The following is a description of a gene set: species: Homo sapiens Any process that modulates the frequency, rate or extent of leukocyte proliferation. Human Gene Set: GOBP_REGULATION_OF_LEUKOCYTE_PROLIFERATION, and this is the list of marker genes: IGF2, RIPK2, PRKAR1A, PRNP, TNFSF8, MYD88, TMEM131L, IL6ST, VAV3 (vav guanine nucleotide exchange factor 3), CBLB, TNFRSF14, IL34, BCL6, GSTP1, NMBR, CD6, MAD1L1, KITLG, CCL8, IL4, HLA-DPB1, MARCHF7, DNAJA3, ITCH, BMI1, DHPS, TACR1, CDKN2A, CD38, LGALS3, MPL, LILRB2, MIR21, IL23R, EBI3, LST1, ATM, SLAMF1, FADD, TGFBR2, CRTAM, GNRH1, MIR181C, IRS2, ZP3, PLA2G2F, JAK2, HES1, HAVCR2, CD86, TNFSF18, GPAM, EPHB2, TGFB1, TMIGD2, PRLR, IGFBP2, GPNMB, CD40LG, CD55, CTNNB1, HMGB1, CD80, CASP3, BST1, CNN2, EPO, CSF2RB, NCK1, IL6, SHH, IL20RB, SCGB1A1, TNFRSF21, IL1A, LILRB4, CD40, FGF10, CCL5, CD81, RC3H1, PTH, TNFSF13, VSIR, VTCN1, CD74, TNFSF13B, FLT3LG, DLG5, TYK2, ATAD5, IL18, ZP4, LYN, BMP4, TLR9, RASSF5, GAL, CORO1A, PTPN6, PTPRC, OCSTAMP, ADA, ERBB2, SFTPD, PTK2, SOS1, TNFRSF13C, MAPK1, CD274, LGALS9, GLMN, MAPK8IP1, AIF1, LRRC32, CSF2, TIRAP, SYK, CD1D, PLA2G5, ZNHIT1, TNFSF9 (TNF superfamily member 9), SDC4, PYCARD, PLA2G2D, STAT5B, IL15, IL4I1, CD37, WNT3A, SPN, CSF1, IL2 (NCBI Gene Id 3558), IKZF3, ZBTB7B, LEP, CDKN1A, ANXA1, STAT6, VCAM1, TNFRSF13B, VSIG4, CD46, RASAL3, XCL1, PNP, CEBPB, ENPP3, PTPN11, CD3E, CD70, NF1, FCRL3, IHH, PKN1, GPR183, CCR2, SOX11, IL7, CHRNB2, CD22, DLG1, AHR, CSF2RA, TNFRSF4, SLC4A2, SELENOK, MIR30B, NR5A2, IL1B, NDFIP1, IL12RB1, TAC1, IL33, FOXP3, CD4, IL21, ICOSLG, ARG2, PAWR, IL5, TNFAIP3, IL2RA, RIPK3, CD24, HLA-G, SLC39A10, LGALS9B, SH3RF1, CD300A, PELI1, BTN2A2, EFNB1, CRP (C-reactive protein), TICAM1, FCGR2B, CR1, LMO1, CARD11, IL5RA, TCF3 (NCBI Gene Id 6929), TNFRSF9, CLECL1P, IGF1, NCKAP1L, PPP3CA, CTLA4, TWSG1, PTPN22, PHF7, AGER (advanced glycosylation end-product specific receptor), GREM1, MAPK3, CD209, TFRC, RAC2, SASH3, NFATC2, BTNL2, TLR4, CCL19, NCK2, INPP5D, HHEX, HLA-E, CD320, KIT, MIR185, IL13, TSPAN32, ARG1, SCRIB, SLC7A1, ZAP70, BID, STAT5A, TYROBP, RPS3, NMB, HLA-DRB1, MIR181B1, FCGR3A, TRAF6, IL23A, TNFSF4, PDCD1LG2, LGALS9C, MNDA, MEF2C (myocyte enhancer factor 2C), PRKCQ, BCL2L1, BTK, SPTA1, PLA2G2A, IL12B, HHLA2, SOS2, FOXJ1, IL12A, LILRB1, MZB1, CD276, BCL2, RPL13A, IRF1, CLEC4G, IDO1, CLCF1, HLA-DPA1, TNFRSF1B, RIPOR2, BTLA, MIF, CLC, CD28, HLA-A, CSF1R, IL10, IL27, BST2, CCDC88B, HLA-DMB, ZNF335, LAPTM5